The following is a description of a gene set: A congenital defect resulting in absence of the lacrimal duct. Lacrimal duct aplasia Human Gene Set: HP_LACRIMAL_DUCT_APLASIA species: Homo sapiens, and this is the list of marker genes: FGF10, FGFR3, FGFR2, TRRAP, SIX1, EYA1, GRIP1, FREM2 (NCBI Gene Id 341640), SIX5, KMT2D, FRAS1 (NCBI Gene Id 84949)